Given this list of marker genes Atp6v1c2 (ATPase, H+ transporting, lysosomal V1 subunit C2), Atp6v1c1 (NCBI Gene Id 98003), Casq2, Clcn5, Ano10, Scnn1b, Best1, Atp2a1 (NCBI Gene Id 11937), Atp6v0b, Atp2c1, Atp6v1b1 (NCBI Gene Id 269766), Best2, Atp6v0c, Asic3, Trpm5, Atp6v1a, Fxyd7, Clcnkb, Atp6v0e, Atp2b4, Atp2b1, Ano8, Trpa1, Atp6v0d2, Atp8a1, Best3, Atp8b2 (ATPase, class I, type 8B, member 2), Trpc4, Bsnd, Nalcn, Fxyd1 (FXYD domain-containing ion transport regulator 1), Atp6v1e2 (NCBI Gene Id 74915), Camk2a, Atp13a4, Camk2b, Atp6v1g1, Calm3, Trpm7, Slc17a3, Clca4b, Atp13a1, Atp8b4, Asic1, Atp2b2, Atp6v1g2 (ATPase, H+ transporting, lysosomal V1 subunit G2), Atp13a5, Atp2a2, Sgk2, Trpc7, Trdn, Trpv5, Atp11b, Tpcn1, Sri, Trpm2, Ano7, Ano2 (anoctamin 2), Pdzd11, Fxyd6, Atp4b, Mcoln2, Sgk1, Atp1b1, Calm1, Atp2a3, Atp6v0a1, Stoml3, Atp7b (NCBI Gene Id 11979), Trpm8, Mcoln3 (mucolipin 3), Atp1b3, Atp6ap1, Ano9, Atp11c, Atp8a2, Ano5, Atp6v0d1, Trpv6, Atp4a, Atp10b, Atp6v1e1, Ryr1, Atp1a2, Atp6v0a4, Clcn6, Ttyh1, Trpc6, Atp10d, Trpc4ap, Atp2b3, Asic4, Atp10a, Uba52, Atp6v1h, Uba52rt, Pln, Casq1, Raf1, Ryr2, Asph, Atp13a2, Ubb, Ttyh2, Trpm4, Ripk3, Clcn7, Ryr3, Tpcn2, Ubc, Mlkl, Rps27a, Fxyd2, Atp6v1d, Ostm1, Trpv1 (transient receptor potential cation channel, subfamily V, member 1), Trpm6, Atp8b1, Atp7a, Trpm3, Ano3, Atp6v1g3, Trpc5, Atp1a1, Ano6, Trpc1, Clca1, Atp6v1b2, Atp6v0e2, Ano1 (NCBI Gene Id 233978), Scnn1a, Atp2c2, Atp11a, Asic5, Trpv4, Stom, Atp9a (ATPase, class II, type 9A), Ripk1, Atp8b3, Atp1b2, Atp9b, Calm2, Clcnka, Nedd4l, Trpv2, Scnn1g, Fxyd4 (FXYD domain-containing ion transport regulator 4), Slc9b1, Ano4, Atp1a4, Clcn1, Camk2d, Fxyd3, Atp6v0a2, Trpv3 (NCBI Gene Id 68700), Trpm1, Asic2, Unc79, Mcoln1, Clca2, Fkbp1b, Atp12a, Trpc3, Tcirg1, Camk2g, Unc80, Wwp1, Ttyh3, Sgk3, Clcn4, Slc9b2, Atp1a3, Clcn2, Atp6v1f, here is a description of the gene set: Ion channel transport Mouse Gene Set: REACTOME_ION_CHANNEL_TRANSPORT species: Mus musculus